The following is a description of a gene set: species: Mus musculus Mouse Gene Set: REACTOME_ISG15_ANTIVIRAL_MECHANISM ISG15 antiviral mechanism, and this is the list of marker genes: Nedd4, Ifit1bl2, Usp18, Flnb, Trim25, Ube2l6, Irf3, Arih1, Uba7, Isg15, Eif4e, Eif4a1, Eif4a3, Rigi, Eif4g3, Eif4a2, Mx2, Mapk3, Eif4g2, Eif2ak2, Eif4e3, Eif4g1, Ppm1b, Ube2n, Becn1, Eif4e2, Plcg1, Ube2e1